Given this list of marker genes TRDN, MGST1, EPHX1, CA2, C8orf82, HOXB7, ITGB8, DSG2, MST1, SEMA4B, AP5B1, ANXA8L1, CCL2, VEGFA, SLC16A4, PAM, SERINC5, NEGR1, MYC, MYH10, TARS2, TRPV6, ATP8A2 (ATPase phospholipid transporting 8A2, NCBI Gene Id 51761), LATS2, ABCB1, SOD3 (superoxide dismutase 3), POLR3H, SPP1, IGFBP7, PPP2R2A, FST, OPN4, SYN3, SAA1, LHX6, SOCS2, HTATIP2, CNTN6, CCDC69, KRT1, IQGAP1, GALK2, ARRDC5, SLC29A1, VCAM1, BICDL1, DKK4, SP6, HAGHL, C3, BCL2, CXCL12, ABCG5, CYP39A1 (cytochrome P450 family 39 subfamily A member 1, NCBI Gene Id 51302), ITPKC, EPB41L3, GTF3C1, STEAP4, TAAR9, GNPNAT1, TTYH3, PDE6B, GPR18, PPP1R1B, RORA, NFKBIZ, NRF1, PRKCE, C1S, FLT1, DOK6, ZAN, CP, NYX, PLD4, ACTA2, IL10, OSMR, KLK11, CXCL9, FSD1, INHBB, CDC14B, SLC26A9, PUS1 (NCBI Gene Id 80324), CCL7, here is a description of the gene set: Up-regulated genes in the expression signature of direct and paracrine viral GPCR signaling in endothelial cells. Kaposi's sarcoma (KS) is the most frequent AIDS-associated malignancy, etiologically linked to the infection with the human herpesvirus 8 (HHV-8/KSHV). This member of the gamma-herpesviridae family encodes 81 open reading frames, several bearing oncogenic potential. A constitutively active virally encoded G protein-coupled receptor (vGPCR) readily induces KS-like lesions when expressed in endothelial cells in vivo, and unmasks the oncogenic potential of other HHV-genes in a paracrine fashion. How vGPCR causes endothelial cell transformation is still not fully understood. Using full-genome microarray analysis we show here that the expression of nuclear factor-kappaB (NF-kappaB)-regulated genes is a prominent feature triggered by vGPCR in cells expressing this viral oncogene and in cells exposed to vGPCR-induced secretions, thus mimicking its paracrine effect. Indeed, vGPCR activates the NF-kappaB pathway potently, and NF-kappaB activation is a hallmark of both human and experimental KS. Of interest, whereas constitutive NF-kappaB signaling is not sufficient to promote endothelial cells transformation, NF-kappaB function is strictly required for vGPCR-induced direct and paracrine neoplasia. Taken together, these results strongly support the role of NF-kappaB regulated genes in KS pathogenesis, thus providing the rationale for the development of novel mechanism-based therapies for this angioproliferative disease. Human Gene Set: MARTIN_VIRAL_GPCR_SIGNALING_UP species: Mus musculus from publication Martin D, Galisteo R, Ji Y, Montaner S, Gutkind JS (PMID 17934524)